Given this list of marker genes Zfc3h1, Hdlbp, Cyfip1 (cytoplasmic FMR1 interacting protein 1), Cep120, Rtp2, Tapt1, Mstn, Fhip1b, Zbtb37, E130308A19Rik, Eif5a2, Paip1, Dcun1d3, Dydc1, Poglut2, Ddhd1, Etfdh, Dll4, Ino80, Stxbp5, Kctd14, Runx1, Mlh3, Ppp2r5a, Plxdc2, Brip1 (BRCA1 interacting protein C-terminal helicase 1), Pth2r, Tm9sf3, Homez, Dyrk2, Qser1, Tbc1d8b, 1810030O07Rik, Abhd3, Zfp513, Acvr2a (NCBI Gene Id 11480), Stxbp4, Arhgef26, Elavl4, Cilk1, Ahctf1, N4bp2l2, Zdhhc21, Rbms1, Mbtps1, Snx3, Ice1, Nxt2, Kat6b, Neto2, Rev3l, Kbtbd6, Slc30a7, Carmil1, Med13, Spopl, Appl2, Ppp4r4, Rnf19a, Xpot, Golga2, Mindy3, Gm14325, Lamc1, Greb1, Ino80d, Prb1b, Rab11b, Rb1cc1, Tnfrsf11b, Lilra6, Hoxb2, Slc20a2, Pcolce2, Hmgb1, Smc3, Atxn7l2, Pip4p2 (NCBI Gene Id 72519), Galnt18, Ghr, Fam234b, Sltm, Sh3gl3, Nbr1, Zfp503, Phldb2, Cadm3, Steap2, Sowahc, Gspt1, Hycc2, Shq1, Nr1d2, Gjc3, Fzd3, Fam76b, Kcns3, Lrp8, En2 (NCBI Gene Id 13799), Wdr13, Ssbp2, Il21, Syde2, Med28, Apaf1, Cxadr, Tmem64, Golm2 (NCBI Gene Id 319996), Rundc3b, Ppp6r3, Ero1b, Ercc6, H3f3a, Blcap, Skp2, Sumo2, Rif1, Rora, Golt1b, Jph1, Mug2, Fbxl3, Pde1c, Uimc1, Lgals8, Ppm1b, Dstn, Igfbp3, Lclat1, Apln, Cdc42se2, Arl5a, Eeig2, Gm14434, Mical2, Lin9, Tktl2, Calcr, Usp24, Epas1, Fsbp, Tcf21, Tmprss11f, Mybl1, Dhx15, Slc4a7, Spin4, Gm13090, Prpsap2, Gm6710, Pptc7, Slc24a5, Ankrd28, Stt3a, Usp47, Arid1a, Wdr26, Ranbp1, Sass6, Epc2, Pparg, Fbxo30, Galnt13, Mtx3, Slc35d3, Irf2bp1, Esp31, Vav3, Trp63, Trrap, Tnip2, Adamts5, B3galt2, Tmem108, Scarb2, Map3k2, Arfrp1, Arid1b, Dcun1d1 (NCBI Gene Id 114893), Zswim5, Ptpre, Sft2d2, Zfpm2, Mre11a (MRE11A homolog A, double strand break repair nuclease), Dcaf12, Cert1, Zfp516, Chuk (NCBI Gene Id 12675), Pds5b, Manea, Nexmif, Myo6, Abhd17c, Cyp2c70, Triqk, Spire1, Rbm24, Zbtb6 (zinc finger and BTB domain containing 6), Nars2, Cobll1, Cdc42, Pik3c2a, Wdr37, Samd8, Gm4724, Calm1, Esco2, Zfp715, Plppr5, Adgrb3, Pm20d2, Crebrf, Zswim6, Grk2, Sgk3, Zfp292, Pcgf3, Il17d, Cr2, Mylip (NCBI Gene Id 353050), Cdc14a, Caprin2, Npas4, Dpy19l3, Slc35b4, Trhde, Bmp4, Zdhhc15, Hnrnph3, Sbno2, Pwwp3b, Eif3j1 (eukaryotic translation initiation factor 3, subunit J1), Fbxo46 (F-box protein 46), R3hdml, Ncoa1, Cwc25, Tshz3, Luzp2, Kat6a, Crem, Rnh1, Peli1, Actr3, Zdhhc17, Phtf2, Klhl2, Ndnf, Pcdhb18, Asb7, Tiam1, Fut9, Arhgef6 (NCBI Gene Id 76697), Capn7, Fgf4, Igf2bp3, Esyt2, Zbtb34 (NCBI Gene Id 241311), Ugt2b37, Ric1, Rbp3, Tmem248 (NCBI Gene Id 77960), Herc3, Fbxo38, Unc80, Fgf13, Vcl, Epn2, Elapor2, Prkar2b, Yes1, D16Ertd472e, Stc1, Gm14308, Tmem209, Senp7 (NCBI Gene Id 77714), Ddx42, Ipmk, Atp6v0c, Pdcd4, Galnt7, Usp13, Snx6, Jam3, Gabpa, Fdx1, Ctsl, Serbp1, Rtn4rl1, Kcnh5, Mtus1, Plxnd1, Svil, Thsd7b, Ubr3, Cdh9, Slc30a9, Lrig3, Bcor, Dixdc1, Tns1, Palld, Krtap20-2, Orc4, Gm6878, Adamts1, Clint1, Xrcc5, Jcad, Phip, Fam114a1, Armc8, Acat3 (NCBI Gene Id 224530), Ppp3r1 (protein phosphatase 3, regulatory subunit B, alpha isoform (calcineurin B, type I)), Slc4a8, Taf8, Kpna4, Glce, Lims1, Sgip1, 1810024B03Rik, Prdm16, Zfp652, Fhl2, Nr2c1, Rimbp2, Acsl4, Ankib1, Atf1, Peds1, Vps54, Med14, Uba3, Btf3l4, Eif2ak3, Tbc1d23, Ssr3, Cntn1, Cntn4, Bmt2, Prl5a1, Pappa2, Gucy1b1, Siva1, Tmem237, Brd1, Atp2c1, Mtf2, Hecw2, Kif13a, Unkl, Map3k1, Arf6, Pou2f1, Aebp2, Rhoa, Smarcad1, Dph5, Mtfr1, Syt6, Lrp12, Fgf12, Pabpc5, Plekhg4, Noc3l, Syap1, Far1, Dlgap2, Heatr3, Tmem245, Lrrc40, Creld2, Rap1gds1, Sh3kbp1, Usp25, Foxn2, Nup205, Rgs17, Fgf7, Tmem33, Ythdf3, Kif23, Plaat3, Erbin, Msrb3, Cacna2d1, Rabgap1l, Nfat5, Arhgap6, Ap4e1, Robo1, Fbxo45, Atad1, Rassf3, G2e3, Vmp1, Ankrd13d, Trank1, Yipf6, Vezt, Plat, Sgpp1, Ifi202b, Csmd3, Rnf111, Ahr, Pum1, Rhobtb3, Otud7b, Tbl1xr1, Nt5c3, Arg1, H3f5, Itga9, Kcnk1, Tgif2, G3bp2, Fam91a1, Sik3, Trappc8, Ivns1abp, Nedd1, A830018L16Rik, Pcdhb3, Nfkb1, Cdh12, Abi3bp, Nckap5, Cav1, Nrarp, Tspan14, Npnt (nephronectin), Elavl2, Hltf, Mphosph9, Map4k3, Zc3h18, Hhip, Tnks2, Itgb1, Cttnbp2, Thsd7a, Hook3 (hook microtubule tethering protein 3), Slk, Cep57, Epha5, Rspo3, Secisbp2l, Mat2a, Srgap1, Atp2a1, Ube2v2, Dnajc25, Ccng2, E130311K13Rik, Zfp449, Cdon, Map4k5, Ccdc162, Pip5k1b (NCBI Gene Id 53355), Dmd, Ptgs2, Btaf1, Gatad1, Ppp1r7, Med12l, Usp9x, Senp5, Ccdc71l, Rab11a, Sbds, Dpp10, Rp2, Rap1a, 1600012H06Rik, Zfp770, Galnt3, Gm2026, Kdm4c, Dusp11, Brwd1, Nog, Ppp2r3a, Arl13b, Ccnc, Fras1, Tpp2, Adamts19, Ubxn7, Tbx5, Kalrn, Pgm3, Tmed5, Actc1, Cask, Ptpn2, Dll1, Eif3j2, Yap1, Jade1 (jade family PHD finger 1), Lmx1a, Atxn7, Psd3, Nus1, Slc25a13, Ammecr1l, Rbm27, Osbpl6, Rad54b, Lztfl1, Ttpa, Selenot, Fancm, Mcmbp, Atp1b1, Slc9a4, Ogt, Tmem106b, Hnf4g, Cwc22, Atp13a3, Fbp1, Als2, Ttbk2, Cyp26b1, Macf1, 1700029F12Rik, Zcchc14, Ppp1r1c, Evi2b, Sgce, Asb3, Srsf6, Nck2, Cxcl14, Tfdp1, Aldh1a3, Bod1l, Frzb, Nfatc3, Cep68, Cadps, Kcna4, Aifm2, Nck1, Azin1, Olfm3 (olfactomedin 3), Cpeb3, Yy1, Tdo2 (tryptophan 2,3-dioxygenase), Pum2, here is a description of the gene set: Mouse Gene Set: MIR_340_5P from publication Chen Y, Wang X (PMID 31504780) Genes predicted to be targets of miRBase v22 microRNA mmu_miR_340_5p in miRDB v6.0 with MirTarget v4 prediction scores > 80 (high confidence targets). species: Mus musculus